The following is a description of a gene set: Genes predicted to be targets of miRBase v22 microRNA hsa-miR-5702 in miRDB v6.0 with MirTarget v4 prediction scores > 80 (high confidence targets). studied in species Homo sapiens from publication Chen Y, Wang X (PMID 31504780) Human Gene Set: MIR5702, and this is the list of marker genes: MAMDC2, MTERF2, ADAM19, NXPH1, CHP1, RAB3B, GAS6, KCNMB1, KRTAP9-8, DLST, HDAC8, MRPL45, MEGF11, MIX23, ZSCAN22, EGFLAM, SV2C, FBXO11, RGL3, GRAP2, ATXN7L1, RAB38, RER1, P3R3URF-PIK3R3, XYLB, CEACAM6, LPP, TPD52, CCSER2, CTNNBIP1, ANXA11, CSNK1A1, LCE2C, ADCYAP1, NREP, ADGRL4, PITPNC1, KIDINS220, BLZF1, DYNAP, RUFY2 (RUN and FYVE domain containing 2), HMGB3, ILDR2, NBPF11, SAP30, MXD3, PIK3R3, GATA4, ETF1, ROCK2, C1QL3, CTNND1, AP3S1, KLHL4, KRTAP9-2, LCE2B, AGTPBP1, HNRNPH1, STK40, MGST3, MDGA2, PLEKHM3, CLIC5, HOMER2, CDYL2, UBE2QL1, CYRIA, ATG5, MIB1, KCNA1, SRP54, PALM2AKAP2, KLF5, ZEB1, TXNRD3, CNTFR, TUSC3, GRIK4